Given this list of marker genes MYRF, FA2H, MIR26A1, PTEN, CLU, here is a description of the gene set: Human Gene Set: GOBP_CENTRAL_NERVOUS_SYSTEM_MYELIN_MAINTENANCE The process in which the structure and material content of mature central nervous system myelin is kept in a functional state. species: Homo sapiens